Given this list of marker genes FGF19, KLB, FGFR4, here is a description of the gene set: FGF21 and FGF19 require betaKlotho for efficient signaling through FGFR1c and FGFR3c. betaKlotho does not interact with 'b' receptor isoforms, and only weakly with FGFR2c. In addition, FGF19, but not FGF21, signals through FGFR4 in a betaKlotho-dependent fashion Reactome Pathway: betaKlotho-mediated ligand binding part of: FGFR4 ligand binding and activation studied in species Homo sapiens